The following is a description of a gene set: Mouse Gene Set: GOBP_G_PROTEIN_COUPLED_PURINERGIC_NUCLEOTIDE_RECEPTOR_SIGNALING_PATHWAY A G protein-coupled receptor signaling pathway initiated by an extracellular purine nucleotide binding to its receptor, and ending with the regulation of a downstream cellular process. studied in species Mus musculus, and this is the list of marker genes: Gpr87, P2ry4, P2ry6, P2ry13, P2ry2, P2ry12, P2ry1, P2ry14